Given this list of marker genes Lrig2, Timp4, Timp3, Timp2, Timp1 (NCBI Gene Id 21857), Ptpn3, Il10, here is a description of the gene set: Any process that stops, prevents, or reduces the frequency, rate or extent of membrane protein ectodomain proteolysis. Mouse Gene Set: GOBP_NEGATIVE_REGULATION_OF_MEMBRANE_PROTEIN_ECTODOMAIN_PROTEOLYSIS species: Mus musculus